The following is a description of a gene set: Human Gene Set: KEGG_MEDICUS_REFERENCE_REGULATION_OF_FIBRINOLYTIC_SYSTEM_PAI Regulation of fibrinolytic system, PAI. Pathway ID: N01524. Pathway type: Reference. Pathway class: nt06514 Coagulation cascade. species: Homo sapiens Pathway Definition from KEGG: PAI -| (PLAU,PLAT), and this is the list of marker genes: SERPINB2, SERPINA5, SERPINE2, PLAU, SERPINE1, PLAT